The following is a description of a gene set: studied in species Homo sapiens Human Gene Set: REACTOME_SYNTHESIS_SECRETION_AND_DEACYLATION_OF_GHRELIN Synthesis, secretion, and deacylation of Ghrelin, and this is the list of marker genes: KLF4, ACHE, SPCS2, SPCS3, INS, PLA2G7, GHRL, LEP, MBOAT4, BCHE, IGF1, SEC11C, GCG, PCSK1, UCN, SPCS1, GH1, SEC11A, CRHR2